Given this list of marker genes RHOA, ALKBH4, ANLN, CHMP2B, CHMP4C, CHMP5, CHMP1A, ARF1 (ADP ribosylation factor 1), CHMP7, VPS4B, CHMP2A, IST1, AURKB, CHMP3, RAB11FIP3, SNX9, CHMP4A, CHMP6, KIF20B, EXOC7, SPAST, MITD1, KLHDC8B, CNTROB, ECT2, SPIRE1, CEP55, SNX33, RAB11A, RACGAP1, IQGAP1, ZFYVE19, ARF6, SNX18, RTKN, NUP62 (NCBI Gene Id 51551), KIF20A, SPART, CHMP4B, CHMP1B, CHMP4BP1, PLEC, SPIRE2, IQGAP2, LUZP1, MTMR4, IQGAP3, VPS4A, MYH9, MTMR3, PDCD6IP, ANXA11, here is a description of the gene set: Human Gene Set: GOBP_CYTOKINETIC_PROCESS A cellular process that is involved in cytokinesis (the division of the cytoplasm of a cell and its separation into two daughter cells). studied in species Homo sapiens